The following is a description of a gene set: species: Homo sapiens Human Gene Set: GOBP_NEGATIVE_REGULATION_OF_MYELOID_LEUKOCYTE_MEDIATED_IMMUNITY Any process that stops, prevents, or reduces the frequency, rate, or extent of myeloid leukocyte mediated immunity., and this is the list of marker genes: FCGR2B, FOXF1, IL13RA2, RABGEF1, LGALS9, SPI1 (NCBI Gene Id 6688), CD84, CCR2, BCR, CD300A, CX3CR1